Given this list of marker genes Dido1, Supt4a, Fbxo38, Zfp707 (NCBI Gene Id 69020), Elapor1, here is a description of the gene set: Mutations in genes encoding ribosomal proteins cause the Minute phenotype in Drosophila and mice, and Diamond-Blackfan syndrome in humans. Here we report two mouse dark skin (Dsk) loci caused by mutations in Rps19 (ribosomal protein S19) and Rps20 (ribosomal protein S20). We identify a common pathophysiologic program in which p53 stabilization stimulates Kit ligand expression, and, consequently, epidermal melanocytosis via a paracrine mechanism. Accumulation of p53 also causes reduced body size and erythrocyte count. These results provide a mechanistic explanation for the diverse collection of phenotypes that accompany reduced dosage of genes encoding ribosomal proteins, and have implications for understanding normal human variation and human disease. Mouse Gene Set: MCGOWAN_RSP6_TARGETS_DN Genes down-regulated by hemizygotic cre-lox knockout of RSP6 in keratinocytes. from publication McGowan KA, Li JZ, Park CY, Beaudry V, Tabor HK, Sabnis AJ, Zhang W, Fuchs H, de Angelis MH, Myers RM, Attardi LD, Barsh GS (PMID 18641651) studied in species Mus musculus